Given this list of marker genes ERLIN2, HNRNPL, BCAT1, PPP3CA, PCDH20, NR4A3, LEF1, CHST9, PEX5L, CLHC1, MAP3K20, B4GALT6, KRAS, ARID4B, RAB3D, SMIM21, FAT2, IPPK, PITPNA, SAR1B, FAM199X, PHIP, R3HDM4, PACC1, POLR2M, CPEB4, RAB22A, TMEM127, NFXL1 (NCBI Gene Id 246220), WDR26, DPY19L4, APPL1, YPEL1, NEFH, CETN3, MRPL19, PSMA8, RAPGEF1, KIF21A, PTPRJ, HAUS2, MRTFB, RAB27B, THAP6, HDAC9, RNLS, PDE4D, ATF2, SGIP1, XRN1 (NCBI Gene Id 54464), SCN2A, SOBP, ARIH2, POGZ, NCKAP5, SGPL1, CTNNB1, BRWD3, ZNF704, YES1, PPP6R3, CITED2, DESI2, GLIS3, ASB4, LRAT, ARGFX, ARIH1, LRP1B, GRM5, SMARCA5 (SWI/SNF related, matrix associated, actin dependent regulator of chromatin, subfamily a, member 5), ZFAT, SALL3, R3HDM1 (R3H domain containing 1), CAPZA2, MECP2, ETF1, KIF5C, FADS1, PTGR2, MFAP3L, ADAM22, KPNA3, LIN7C, USP46, ANO5, PBRM1, DCK, APPBP2, RBMXL1, GPR137C, ZEB2, SGMS2, CCNG1, ZNF652, ZNF367, RPS6KA5, STRN3, ARHGAP12, WASF3, ZNF850, SPOCK3, MSI2, ZMYND11 (zinc finger MYND-type containing 11), OIP5, AICDA, SUZ12, ZBTB7A, TRIM33, CADM2, CACNA2D1, SOS1, N4BP2, PTH, NRIP1, PLG (plasminogen), CDH6, SUCO, CSMD3, CRIM1, BMPR2, RAB5C, TMEM182, DPY19L1, ST13 (NCBI Gene Id 8937), YY1 (NCBI Gene Id 7528), TBC1D8B (NCBI Gene Id 54885), RLIM, ADO, TXN, SERTAD2 (NCBI Gene Id 9792), KLF9, OSBPL5, ADAMTS9, ZDHHC21, EPHA5, TENM1, C1orf162, UBE2Q2, MFSD5, COL3A1, ADAMTS4, PRKAR2B (NCBI Gene Id 5577), TGDS, ZNF451, ERBIN, RBBP7, POU5F1, AP1S2, USP15, B4GALT5, MBOAT2, NCAPG2, PGAP1, UBE3C, ITGB1, PHLPP2, RANBP3, UBE2D3, PHC3, SGTB, NAALAD2, SPOPL (speckle type BTB/POZ protein like), ANKRD17, UBE2K (NCBI Gene Id 84819), BMP2, GNG10, MYT1L, DLEC1, ATG16L1, TMTC3, TMEM128, LRIG1, GPD2, SNTB2 (NCBI Gene Id 6645), BICC1, NCAM1, CREB1, TPD52, GIPC2, DYNC1LI2, SLC4A4, USP28, EIF4A1, EREG, MTMR10, STX11, SLC38A2, ITGA2, PTPN14, LMAN1, NABP1 (nucleic acid binding protein 1), GCOM1, ZFP36L2, BCL2L11, ZDHHC17, HS2ST1, EPHA7 (EPH receptor A7), SMOC1, SS18, SERP1, UBR5, FGF23, CNTLN, DPYSL2, VPS29, ZNF106, ZC3H12C, ADGRB3, PCDHB7, ZNF711, USP31, FUBP1, PDIK1L, SPOCK1, DPP8, NEDD4, BBX (BBX high mobility group box domain containing), RYK, ITGB8, RNF217, UTP25, AMER2, ZNF493, FRMD4A, SH3BP4, HDX, TNRC6B, PAK3, ACER3, PMP22, NCBP2, SYT16, TRPS1, PPP1R15B, PLAG1, NDST3, ERO1A, EXOC5, TOX, UBR3, GRIP1, GJA3, ZNF318, FLRT3, PAG1, AGFG1, NTNG1, HNRNPDL, OTOGL (NCBI Gene Id 651200), NCOA1, SLC4A7, RALGAPB, OSBPL8, SLAIN2, HSFY2, HSFY1 (NCBI Gene Id 86614), ABCA8, TMEM170A, ZC3H6, CCDC152, ZNF234, ADD1, STXBP5 (NCBI Gene Id 134957), ZNF484, CHIC1, RPS6KA3, CLXN, RYBP, DENND4A, TMEM131L, ECE1, DGAT2, GPN3, AQP3, MARCHF5 (membrane associated ring-CH-type finger 5), CHD1, TCEA1, MICU3 (NCBI Gene Id 286097), SGPP2, ZCCHC8 (zinc finger CCHC-type containing 8), EPB41L5, STK17B, USP21, FOXL1, HOXD13, KMT2A, C2orf69, CLOCK, RBM44, KATNAL1, SPAG9, AFDN, FBXO22, SLC24A4, PPP2R2A, PTPN2, MTF2, TNS1, RRAS2, IGSF10, SET, SLC2A13, USP3, ZNF99, FOXG1, INTS5, ATXN1, NFKB1, SLC6A6, PRKACB, IGF1R, BRWD1, STIM2, PAPOLA, SNX9, PPARA, A1CF, STK35, PLGLB2, ADARB1, MAP4K3, LPGAT1, SGCZ, NAIF1, CCSER1, KPNA2 (karyopherin subunit alpha 2), CHRAC1, KDM5B, ZFHX4, MDGA2, GPC6, CMBL, CEBPZOS, MYCN, CDC37L1, LRRN1, CD2AP, B3GALT2, BTG1, DOCK4, GPD1L, MRPS25, KCNAB1, REEP3, PLGLB1, CXCL5, EXOC6, C11orf96, PARP12, SKIL, HNF1A, LEPROTL1, SMIM15, MAP3K2, TCF4, POU2F1, GDA, RABGAP1L, SSX2IP, MAPK1, GUCY1A2, FZD2, ZNF737, RASGEF1A, PTBP3, CEP44, DCUN1D5, CREB5, NAPB, ANAPC11, PIK3C2A, TENM4, FEZ2, RBMX, MIER3, AQP4, TP63, PPARG, NEO1, GAB1, TBCEL, KLHL23, DSCC1, PLOD1, OPRM1, TDP1, TOPORS, CDH1, TMCC1, RNF212B, TRIM2, PAIP1, RNF38, IKZF2, SMG1, CPNE8, LMX1A, POU5F1B, HAS2, ZBTB41, YIPF2, CAMK2D, LCOR, MITD1, BPNT2, ATAD2, THAP1 (NCBI Gene Id 55145), EPRS1, ARHGAP1, OLAH, TAOK1, VEZF1, CXCL11, TMEM170B, PKN2, ZNF217, OTUD4, CLIP4, MARCKSL1, CFL2, PPM1G, MOB1B, MAP4K5, PHTF2, YTHDC1, DGKH, here is a description of the gene set: species: Homo sapiens from publication Chen Y, Wang X (PMID 31504780) Genes predicted to be targets of miRBase v22 microRNA hsa-miR-548az-5p in miRDB v6.0 with MirTarget v4 prediction scores > 80 (high confidence targets). Human Gene Set: MIR548AZ_5P